The following is a description of a gene set: studied in species Mus musculus Mouse Gene Set: MIR_6394 from publication Chen Y, Wang X (PMID 31504780) Genes predicted to be targets of miRBase v22 microRNA mmu_miR_6394 in miRDB v6.0 with MirTarget v4 prediction scores > 80 (high confidence targets)., and this is the list of marker genes: Mcl1, Enpep, Ppat, Ajuba, Syvn1, Ubr7, Cyyr1, Sema4d, Mobp, Fut1, Tafazzin, Anpep, Lin28a, Trim71, M6pr, Il6ra, Eif1ad, Tmem132e, Sel1l, Suv39h1, Fam83h, Tgoln1, Ikzf4, Dicer1, Chtf8, Nup210, Gpr153 (NCBI Gene Id 68907), Sgpl1, 2610528J11Rik, Samd10, Nr6a1, Kbtbd13, Ercc6l2, Nkapd1, Kcnip3, Ptpn1, Dtx4, Niban2, Rufy3, Abhd3, Gal3st2, Tmem72, Mtf1, Ulk3, Dhx33, Edn1, Tada3, Sema4b, Dus1l (dihydrouridine synthase 1 like), Slc35a4, Brip1, Tbc1d8b, Serpinb9d, Jade2, Cdc37l1, Nipal4, Kmt5c, Cbx7, Alpk3, Shtn1 (shootin 1), Ppp2r5c, Ist1, Bhlhe41, Nrm, Bmf, Zfp704, Mfsd13a, Man1b1, Was, Cdk16 (cyclin dependent kinase 16), Zswim5, Tmem120b, Nim1k, Klhl25, Cnnm1, Slc39a9, Fbxw4, Gtpbp2, Scarb1 (scavenger receptor class B, member 1), Dvl1, Ebf4, Galnt5, Prdm2 (NCBI Gene Id 74588), Cntd1, Hdac3, Osgep, Ppp4r3a, Atxn1, Nckap5l, Zfp518a, Tnfaip3 (NCBI Gene Id 21929), Borcs6, Hic2, Ier2, Neu1, Lrrc10b, Klhl24, Cdh5, Lrp4, Bag4 (BCL2-associated athanogene 4), Zscan29, Sarm1, Daam1, Kctd21, Dram2, Rbak, Tle3, Pin1, Nfkbib, Retreg2, Abhd6, Cdk19, Sh3bp5l (SH3 binding domain protein 5 like), Pafah1b1, Ptpn7, Mfsd9, Gpatch8, Trem6l, Rbm20, Elovl6, Bap1, Rhoq, Nhsl3, Scn4a, Hapln1, Zbtb37, Sec14l2, Abcc5, Prss33, Cyth1, Dennd6a, Phactr3, Klf13, Acads, Khnyn (NCBI Gene Id 69626), Zfp523, Cdc42se1, Grb10, Sbno1, Slc25a35, Eaf1, Cgref1, Eif4ebp1, Sh3tc2, Stat3, Prtg, Smurf1, Pcsk7, Slc46a3, Mlf2, E2f2 (NCBI Gene Id 329958), Plxna1, Tmem25, Mknk2, Ovol1 (NCBI Gene Id 18426), Tor2a, Lfng, Usp38, Nbeal2, Gal3st2c, Cdr2l, Grsf1, Xirp1, Rfxank, Gga2, Rasgef1a, Rfx3, Kcnk10, Myt1, Dynlt3, Nin, Arid3b, Il16, Lin28b, Glb1l2, Fam234b, Cyp24a1, Tmprss13, Zswim6 (NCBI Gene Id 67263), Mfhas1, Casp2, Slc6a17, Osbpl9, Kcna1, Tspan12, Tril, Kcns3, Abcb11, Irf4, AU040320, Ttc7, Gcnt1, Scn2b, Ier3ip1, Slitrk6, Fam118a, Necab3, Map3k11, Ceacam1, Rbm7, Itga8, Pcgf6, Dnajc14, D17H6S53E, Vdr, Bet1, Bak1, Tnfsf4, Sema4c, Sptb, Lhx8, Golga5, Eva1a, Diras1, Rora, Ncan, Ppp2ca, Pi4k2b, Ctnnal1, Cln6, Lactb, Plekhm3, Galnt14, Grhl1, Scara5, Orc2, Ankrd50, Triap1, Ttc29, Crb2, Tmtc2, Bnip2, Ahrr, Crem, Tbc1d1, Ppm1h, Tjap1, Zfp488, Arid3a, Cdc42bpg, Hif1an, Ino80d, Lclat1, Grk4, Ndufs4, Alg6, Stard13, Ninl, Lif, Blzf1, Mamdc2, Tent5a, Zbtb7a, Abtb1, Dock3, Sertad3, Zfp62, Podxl, Ube2g1, Zfp408, Scgb1b30, Cacna1b, Acer2, Zfyve1, Npl, Mapre2, P2rx4, Rap1a, Trp53inp1, Sstr3, Vps37b, Klc2, Speg, Zdhhc9 (zinc finger, DHHC domain containing 9), Retreg3, Ccnj (NCBI Gene Id 240665), Atp11a, Slc25a15, Frmd5, Tmem161b, Vps4b, Zbtb34, Msrb3, Cgn, Prdm1